The following is a description of a gene set: from publication Chen Y, Wang X (PMID 31504780) studied in species Homo sapiens Human Gene Set: MIR664A_3P Genes predicted to be targets of miRBase v22 microRNA hsa-miR-664a-3p in miRDB v6.0 with MirTarget v4 prediction scores > 80 (high confidence targets)., and this is the list of marker genes: TMEM220, ZEB1 (NCBI Gene Id 6935), SLC10A7, AFF4, ARMT1, C1QTNF7, RHOT1, CNKSR2, KDM4C, ITGA2, SPRING1, YTHDC2, ZNF570, RSBN1, IPO7, SLC1A4, PPP4R4, GNG2, NUDT12, IPMK (NCBI Gene Id 253430), FRYL, ZC3H12C, MSH3, SLC24A4, CPE, MAP3K20, TWSG1, CORO1C, BNIP2, PALS2, POU3F2, TNFSF8, ADH4, C1D, BRWD1, NAPEPLD, TMEM255A, KIAA1549L, C4orf17, PTP4A2, CFAP97, PTGS2, RLIG1, ACSL6, BRINP3, MEP1A, APOOL, PAX3, GPRASP3, DSE, AK6, CNTN5, TWF1, STAM, CT47A10, STAU2, SPA17, DNAJC1, ICOS, PHKA1, HERC1, ZNF704, TMEM62, ABHD6, IGF2BP1, ELAPOR2, RFX3, LRRC8B, ADCY7, DNAJB11, ZNF682, CYP26A1, FZD3, IMPACT, TXNRD3, SFI1, IFIT5, SLC10A4, BEND4, ENAH, PIK3CA, GPR180, PCLO, GAL3ST4, DRAM1, CHIC1, SLC10A2, ADGRG6, ANKRD28, PCDHB11, ZNF280D, GHSR, RNF180, QKI, TMX4, ATXN7, STRC, RAB1A, MTERF3, IGSF11 (immunoglobulin superfamily member 11), KIF3A, MED13, GCSAML, SLC9B1, ETNK1, LMO7DN, SAMD4B, SERINC1, PDE11A, GLT6D1, ABI2, MARCHF2, SH3BGRL, TOX3, YIPF6, IL17RB, CYBRD1, PLEKHB1, PRR18, HTR2A, SNAP25, LETM2, PTPN2, FAM133B, TRAK2, RAB3IP, OGFRL1, JKAMP, LRRCC1, TLR8, CYBB, NUTM1, UVRAG, SLC35E1, CCSAP, MMP13, ADGRF3, GABRG1, ZNF782, ARHGAP28, ZNF680, GJA1, CT47A5, CDC14A, FOXJ3, PLAG1, LYPD6, SYNRG, ZBTB44, ARFGEF3, ATP6V1B2, MAPK6, CRIPTO, CCDC179, CT47A8, REPIN1, ZNF354B, PRSS35, ZC3H12B, PTPN4, AHCTF1, IFNG, SLC2A13, DLC1, CD8A, PIGP, MTDH, ZNF84, GABRB2, LGR4, RBFOX1, NPY1R, TET2, CT47A1, NLN, RRM2, TMEM260, ANKRD6, PSMC2, NR2C1, CT47A4, IL1A, HDAC8, POLQ, KLF12, DIRAS3, SPSB4, PCGF5, SHB, USP49, NMI, MBNL3, TAF5L, MYH15 (myosin heavy chain 15), TRPA1, ZNF274, TBX15 (T-box transcription factor 15), KCMF1, STRAP, RTN1, ZRANB3, PTPRN2, CWC27 (NCBI Gene Id 10283), XK, FAM133A, ST8SIA2, FUT9, GPATCH4, CNGA1, ADGRB3, R3HDM4, NIP7, SLC9A4, DMXL2, ZNF600, BCAT1, RNF157, CCL2, CT47A11, EBF2, COPG1, GPHN, PCTP, WDR76, KDM4B, SAMD8, TMEM74, SLITRK4, GPR34, BLOC1S6, RGS5, FCRLB, CSAD, HOXD8, SLC38A2, DENND4A, RBM41, ZDHHC21, INO80D, YTHDF3, CCDC81, SLC25A40, UBE2D3, MID2, MARCHF7, RBAK, C11orf54, C15orf32, TCF7L2, SIMC1 (SUMO interacting motifs containing 1), ARMC8, HAPSTR1, ZNF506, AAK1, NECAB1, ELMOD1, POC1B, ANO3, DENND1B, TMEM45A, PAX1, PDK3, TCEAL7, FAR1, OSBPL6, KIAA1549, C5AR1, CFDP1, PTPRC, GPR155, STT3A, LIF, RPP30, ARL8B, CT47A7, ZNF268, ABHD11, GUCY1A2, KLHL4, KIF11, DENND4C, UHRF1, SH3TC2, IRF2 (interferon regulatory factor 2), ANKRD44, CAVIN4, RPAP2, ITPRID2, ATP8A1, FAM83B, ARMCX3, ARID1A, FBXO33, SMAD4, ZNF565, VDAC2, RBM26, ARID4B, URI1, SSPN, SSH2, ARHGAP33, BRWD3 (NCBI Gene Id 254065), MGST1, RAB27B, RAPGEF6, NCS1, SEMA5A, SMIM14, SPCS3, NPY2R, LRRC8C, HOOK3, CRY1, PICALM, SMIM15, CEP76, MAP3K2, ZBTB41, RFX6, FAM20B, LRRC7, TBR1, NABP1, ASB14, DCUN1D5, USP25, DBT, ZNF626, LRP6, FAM200C, RELCH, PDE4D, SEC24C, MEIOC, CT47A12 (cancer/testis antigen family 47 member A12), SLC16A7, CCNC, SEC62, ATP5MC3, MREG, BACH2, C18orf54, RAB2A, ALKBH1, DELE1, ZNF423, LARP1B, BCL2A1, CFL2, GTF3C4, CSMD3, HNRNPDL, P2RY1, C9orf40, PDPK1, MSTN, NRAS, IQGAP2, SEMA3D, CT47A6, ABCB10, MDGA2, ZNF532, NOL3, SPATA9, KCNV1, NCAPD2, ZNF334, MAP2, ZSWIM2, ZDBF2, TRPC5OS, UBA6, ZNF420, NUFIP2, NFIB, KLHL5, NEK7, OSBPL8 (oxysterol binding protein like 8), PTER, CTTNBP2, GMCL1, PHIP, ZFYVE1, LYSET, PLP2, ADCYAP1, ZNF888, POLR1B, BCAR3, GABRP, GPC6, FUT2, SUCLG2, KMT2A, CT47A2, RBM17, GLRA3, RREB1, RB1CC1, CT47A9, CD163L1, KLHL2, HS6ST3, ZNF710, SCO1, SESTD1, CT47A3, ZFP30, MYOG, C8orf34, ENKUR, LPP, AGFG1, FMN2